Given this list of marker genes CEBPA, PC, ECH1, AP3S1, AQP7, SELENBP1, CDKN2C, DGAT1, FXYD1, ADRB3, APOC4, BCKDHA, G0S2, PPARG, REEP5, SLC2A4, ALDH1A1, CIB2, PCK1 (phosphoenolpyruvate carboxykinase 1), HIPK3, PLA2G6, TALDO1, QKI, TST (NCBI Gene Id 96794), GPD1, AK2, SORBS1, ADIPOQ, ENTPD5, ALAD, RETN, ESYT1, CFD, ACSL1, ACOX1, ACADM, SCARB1, DHRS3, AATK, LAMA4, CBX4, NR1H3, RNF11, AOC3, DBI, ARL4A (ADP ribosylation factor like GTPase 4A), ALAS1, NRIP1, TOB1, COL15A1, ITGA6, ORM1, CIDEC, MMUT, UCK1, HK2, IRX3, RGS2, PEX11A, IDH3G, PLIN4, NNMT, IDH1, PFKFB1, LTC4S, CEBPG, PXMP2, TPP2 (NCBI Gene Id 7174), FASN, GPAM, RASD1, HIPK2, HSD17B4, ACADS, FABP5, ME1, LPL, ABCD2, NFS1 (NFS1 cysteine desulfurase), here is a description of the gene set: Human Gene Set: RUAN_RESPONSE_TO_TNF_DN Adipocyte abundant genes down-regulated in 3T3-L1 cells (fibroblasts induced to differentiate to adipocytes) in response to TNF. Troglitazone (TGZ), a member of the thiazolidinedione class of anti-diabetic compounds and a peroxisome proliferator activator receptor-gamma (PPAR-gamma) agonist, restores systemic insulin sensitivity and improves the full insulin resistance syndrome in vivo. The mechanisms underlying its in vivo function are not understood. Here we investigated the potential functional interaction between PPAR-gamma and NF-kappaB in adipocytes. We show that TGZ selectively blocked tumor necrosis factor-alpha-induced and NF-kappaB-dependent repression of multiple adipocyte-specific genes and induction of growth phase and other genes. This occurs without interfering with NF-kappaB expression, activation, nuclear translocation, or DNA binding and without suppressing NF-kappaB-dependent survival signals. Notably, the expressions of some tumor necrosis factor-alpha-induced genes in adipocytes were unaffected by PPAR-gamma activation. In reporter gene assays in HeLa cells, ectopic expression of PPAR-gamma abolished induction of a NF-kappaB-responsive reporter gene by the p65 subunit (RelA) of NF-kappaB, and the inhibition was further enhanced in the presence of TGZ. Conversely, overexpression of p65 inhibited induction of a PPAR-gamma-responsive reporter gene by activated PPAR-gamma in a dose-dependent manner. The inhibitory effect was independent of the presence of NF-kappaB-binding sites in the promoter region. Other NF-kappaB family members, p50 and c-Rel as well as the S276A mutant of p65, blocked PPAR-gamma-mediated gene transcription less effectively. Thus, p65 antagonizes the transcriptional regulatory activity of PPAR-gamma in adipocytes, and PPAR-gamma activation can at least partially override the inhibitory effects of p65 on the expression of key adipocyte genes. Our data suggest that inhibition of NF-kappaB activity is a mechanism by which PPAR-gamma agonists improve insulin sensitivity in vivo and that adipocyte NF-kappaB is a potential therapeutic target for obesity-linked type 2 diabetes. from publication Ruan H, Pownall HJ, Lodish HF (PMID 12732648) studied in species Mus musculus